Given this list of marker genes MYBPC2, SLMAP (NCBI Gene Id 7871), ANK1, ENO1, MYOM3, MYBPH, SPTBN1, LMOD2, MYBPC1, MYBPC3, KLHL41, CRYAB, ANK2, NBR1, TTN, PPP2R5A, CMYA5, OBSCN, KCTD6 (potassium channel tetramerization domain containing 6), LRRC39, MYOM2, LMOD3, TRIM63, SMPX, S100A1 (NCBI Gene Id 6271), MYOM1, ALDOA, SMTNL1, OBSL1, here is a description of the gene set: Human Gene Set: GOCC_M_BAND The midline of aligned thick filaments in a sarcomere; location of specific proteins that link thick filaments. Depending on muscle type the M band consists of different numbers of M lines. studied in species Homo sapiens